The following is a description of a gene set: studied in species Homo sapiens Catalysis of the reaction: ADP-ribose + H2O = AMP + D-ribose 5-phosphate. Human Gene Set: GOMF_ADP_RIBOSE_DIPHOSPHATASE_ACTIVITY, and this is the list of marker genes: TRPM2, NUDT6, NUDT9, ADPRM, NUDT5, NUDT14